Given this list of marker genes SLC25A20, PPP1R13L, AK2, COL12A1, ACACA, MRPS18B, CHIC1, ADAMTS9, SNRPC, ATP13A5, PENK, NEFH, PUS1, DAZAP1, GCG, IFI27L2, MREG, NUDT5, C16orf86, CADM1, DDX20, NRIP1, HSH2D, EED, TIMELESS, ACOD1, ANKRD28, THBS4, CTPS1, BATF2 (basic leucine zipper ATF-like transcription factor 2), TRPM5 (NCBI Gene Id 29850), LBX2, TM4SF1, UBALD2, SHMT2, AHR, LAMA2, PSPC1, SDR39U1, SPINK5, GZMB, MRPL32, SCAF4, SNHG3, C8orf76, HELZ2, SEMA5B, IPO4, CISH, GLDC, PMCH, MOGAT2, BST2, BEST2, RABL3, UTP3, PLA2G2E, PRKCSH, PASK, GPR65, MOB3B, FAM86B2, AVEN, CLDN1, ISY1, RCL1, NFKBIE, TBC1D24, FURIN, GSPT1, NOS2, SH3RF3, NFKBIZ, MLEC, GPR171, PMEPA1, NELFE, SMYD5, SPP1, LAG3 (NCBI Gene Id 3902), SLC19A1, PLA2G12B, TIMM9, MTFR2 (mitochondrial fission regulator 2), LTV1, SRPRA, NECTIN3, LPCAT1, DOK4, TBC1D8, HABP2, ABHD17B, FKBP5, JUN, FAM222A, MLKL, CGA, BRCC3, EPS8L3, MGARP (NCBI Gene Id 84709), RILPL2, SHMT1, ALDH1L2, TRPV6, CSRNP1, CABP4, HIRIP3, COX17, KDELR3, NOVA2, TAT, PECR, SOCS3, NKAIN4, MIF, ALKBH1, MANF, ICAM1, IFIH1, RBM19, KDELR2, UFD1, ANP32B, EBNA1BP2, SAPCD2, TNFRSF25, CTBP2, KIAA0825, MAFF, SPCS2, SNCAIP, YARS2, CARNMT1, KRTAP19-3, COQ2, ISG15, SEMA6D, TM4SF20, CNTFR, ICA1, TUBG1, TEKT2, SRRT, EHD1, FGG, UTP23, C1orf131, GNG12, TGM2, CMAS, SMTNL1, SLC15A3, TSG101, CLPB, KLK4, OSM (NCBI Gene Id 5008), NOL9, TNFAIP2, PKMYT1, RASSF9, MFSD2A (NCBI Gene Id 84879), LIX1L, CGAS, SCO1, KAT2A, RSL1D1, CRIP3, MTHFD2, MTCL3, MC5R, IL4I1, PRPS1, MXD1, CYB5R2, ANKRD1, SLC34A1, DUS4L, CCL4, PHYHIP, RPUSD1 (RNA pseudouridine synthase domain containing 1), SLFN13, CYP2S1, SFTPA1, ILRUN (NCBI Gene Id 79138), SLC26A8, DDX56, DGKG, TMEM178A, DHODH, NCAM2, BASP1, AHSA1, CCDC116, XPO4, HS3ST4, GPR155, FLNC, KCNG1, GPR150, PAQR3, here is a description of the gene set: Human Gene Set: GSE11961_FOLLICULAR_BCELL_VS_PLASMA_CELL_DAY7_UP studied in species Homo sapiens To obtain insight into the genetic basis of the increase of functional activity of memory B cells over time, we compared the gene expression profiles of day 7 and day 40 NP-specific/IgG1 memory B cells, GC B cells and plasma cells in immunized WT mice and naïve B cells, before and after activation in vitro. Genes up-regulated in follicular B cells versus day 7 plasma cells. from publication Kaji T, Ishige A, Hikida M, Taka J, Hijikata A, Kubo M, Nagashima T, Takahashi Y, Kurosaki T, Okada M, Ohara O, Rajewsky K, Takemori T (PMID 23027924)